Given this list of marker genes Parp9, Irgm1, Txk, Hpx, Nlrc5, Igtp, Med1, Irgm2, here is a description of the gene set: Mouse Gene Set: GOBP_POSITIVE_REGULATION_OF_RESPONSE_TO_TYPE_II_INTERFERON species: Mus musculus Any process that increases the rate, frequency or extent of a response to type II interferon (interferon-gamma). Response to interferon gamma is a change in state or activity of a cell or an organism (in terms of movement, secretion, enzyme production, gene expression, etc.) as a result of an interferon-gamma stimulus.